The following is a description of a gene set: studied in species Homo sapiens Human Gene Set: AGUIRRE_PANCREATIC_CANCER_COPY_NUMBER_DN The pancreatic adenocarcinoma genome harbors multiple amplifications and deletions, pointing to the existence of numerous oncogenes and tumor suppressor genes driving the genesis and progression of this lethal cancer. Here, array comparative genomic hybridization on a cDNA microarray platform and informatics tools have been used to define the copy number alterations in a panel of 24 pancreatic adenocarcinoma cell lines and 13 primary tumor specimens. This high-resolution genomic analysis has identified all known regional gains and losses as well as many previously uncharacterized highly recurrent copy number alterations. A systematic prioritization scheme has selected 64 focal minimal common regions (MCRs) of recurrent copy number change. These MCRs possess a median size of 2.7 megabases (Mb), with 21 (33%) MCRs spanning 1 Mb or less (median of 0.33 Mb) and possessing an average of 15 annotated genes. Furthermore, complementary expression profile analysis of a significant fraction of the genes residing within these 64 prioritized MCRs has enabled the identification of a subset of candidates with statistically significant association between gene dosage and mRNA expression. Thus, the integration of DNA and RNA profiles provides a highly productive entry point for the discovery of genes involved in the pathogenesis of pancreatic adenocarcinoma. Down-regulated genes whose expression correlates with copy number losses in pancreatic adenocarcinoma cell lines and primary tumor specimens. from publication Aguirre AJ, Brennan C, Bailey G, Sinha R, Feng B, Leo C, Zhang Y, Zhang J, Gans JD, Bardeesy N, Cauwels C, Cordon-Cardo C, Redston MS, DePinho RA, Chin L (PMID 15199222), and this is the list of marker genes: TST, MTAP, FKBP11, RRAGA, HOXC4, QRSL1, RNF19B, VLDLR, EIF4B, NRG1, MN1, GNS, RACGAP1, PUM3, SLC66A2, SH3BP1, TAB1, TSPYL1, UFSP2, KITLG, MECR, PDGFB, SNAPC3, KCTD17, CARD10, GTPBP1, PDPK1, HNRNPA1, STMN1, PPIL6, DCTN6, RAB36, FUCA1, FBXW7, CLIC4, SLC35E3, MGAT3, YARS1, MAK16, SRRM2, SCAF11, KLHL9, PSD3, CSNK1E, ZBTB24, HBS1L, DUSP6, MYH9 (myosin heavy chain 9), KIR2DL1, PDSS2, GATB, GOSR2, CAND1, GGA1, LEMD3, THOC5, SUN2 (NCBI Gene Id 25777), HAND2, CRYBA4, RPS6, SGSM3, YWHAH, GSTT1, TMEM43, GSR, PATZ1, SEC63, PLPBP, SMARCA2, HDAC2, SNX3, PLGRKT, CD164, HEBP2, APOL3, AMDHD2, SEC14L2, SMUG1, MBP, PDXP-DT, SMAGP, RARG, RLIG1, RANBP6, PRMT2, TIMP3, GRM1, ISOC1, REV3L, PTTG1IP, PFDN5, XPC, CTDP1 (CTD phosphatase subunit 1), C6orf120, RSRP1, ACVR1B, CHEK2, PIK3C3, TMBIM4, GMEB1, SPATS2, MFSD5, TBK1, NFATC1, SMPD2 (NCBI Gene Id 6610), HMGN2 (NCBI Gene Id 94860), UBXN8, PISD, KDM1A, TOM1, SUMO3, PHF10, AHI1, ATP6V0C, KANSL2, CCDC59, PIAS2, PPP5C, ASCC2, ASF1A, RBFOX2, MICAL1, IRF2, BTG1, COPZ1, POM121L4P, ATP2B1, HECA, CDK19, IL20RA, VDR, SF3A1, WASF1, HPS4, PRKAG1, CBX5, ERLIN2, HOXC11, TXNL4A, SLC48A1, CD63, ATG5, TXN2, E2F2, FIG4, PRPF31, CACNB3, TOMM22, EXTL3, PDCD1LG2, EIF3D, ALPL, GPATCH3, PSIP1, MFNG, RPS6KA1, AK2, PLEKHA8P1, MIEF1, ADNP2, NKAIN1, LRP2BP, SRRM1, PPP2CB, HMGCL, PHC2, DYRK2, SNRPD3, TFCP2, AMD1, LEPROTL1, NFIB, LYPLA2, DMC1, ELOB, LSM3, RAP1B, TAF12, IGLL1, SMARCB1, NAT1, TMBIM6, CBY1, SLC11A2, FOCAD, RBPMS, ARF3, DAZAP2, DEPDC5, MAP3K5, MCRS1, CDKN2AIP, TWF1, TFIP11, INTS9, DCTD, SRSF4, CDC40, GCAT, BCR, DDX23, ZNF593, ATF4, HAUS6, MYG1, KDELR3, BLOC1S1, CEP290, GALE, MMP11, ZPR1, CCDC28A, JOSD1, PIGV, ATP6V1B2, PPP1R12A, POLR2F (RNA polymerase II, I and III subunit F), NCR1, OR7E47P, XPOT, LMBR1L, SARAF, TTI2, GALNT7, GTF2E2, ATP5F1A, TRNAU1AP, YTHDF2, MPST, YEATS4, SOCS6, RBFA, SFI1, ORMDL2, CCT2, APOL6, APOL2